The following is a description of a gene set: studied in species Homo sapiens Genes up-regulated in macrophages: untreated versus 48h after M. bovis BCG infection. from publication Qualls JE, Neale G, Smith AM, Koo MS, DeFreitas AA, Zhang H, Kaplan G, Watowich SS, Murray PJ (PMID 20716764) Human Gene Set: GSE22935_UNSTIM_VS_48H_MBOVIS_BCG_STIM_MACROPHAGE_UP Nitric oxide (NO) produced by macrophages (MØs) is toxic to both host tissues and invading pathogens and its regulation is therefore essential to suppress host cytotoxicity. MØ arginase 1 (Arg1) inhibits NO production by competing with NO synthases for arginine, the common substrate of NO synthases and arginases. Two signal transduction pathways control Arg1 expression in MØs. First, a MyD88-dependent pathway induces Arg1 in intracellular infections, while a second Stat6-dependent pathway is required for Arg1 expression in alternativelyactivated MØs. We found that mycobacteria-infected MØs produce soluble factors that induce Arg1 in an autocrine-paracrine manner via Stat3. We identify these factors as IL-6, IL-10 and GCSF. We further establish that Arg1 expression is controlled by the MyD88-dependent production of IL-6, IL-10 and G-CSF rather than cell intrinsic MyD88 signaling to Arg1. Our data reveal the MyD88-dependent pathway of Arg1induction following BCG infection requires Stat3 activation and may result in the development of an immunosuppressive niche in granulomas due to the induced Arg1 production in surrounding uninfected MØs, and this is the list of marker genes: FAM3D, NAAA, RELN (reelin), GSTT2, THTPA, TBC1D32, CAMKK1, RYR3, ALX1, KLF1, DIO3OS, KIAA0930 (NCBI Gene Id 50610), SLC38A3 (NCBI Gene Id 10991), SMYD1, EFHC2, ATP2C2, SH3GL3, CLTB, OTOS, NCF1, PLXNA3, OLR1, CTNNA2, LYNX1, IFITM5, GPR39, FZD1, EXTL1, CDH23, MYOZ3, B3GALT6, C15orf39, GPX4, SERPINC1, PKP1, TRAPPC6B, MMAB, CD79B, NOS3, PRELP, IMPA1, EYA2, COL19A1, FAM170B, UNC119, AZIN2, DYNC2I1, GLRB, LRAT, CA3, LYRM7, HIF3A, MESD, NRGN, AKAP11, ADAM19, VILL, CPNE6, CPA5, HLA-DMB (NCBI Gene Id 3109), SMARCD3, CAMK2N1, IZUMO1R, SLC17A2, EXPH5, NPAS3, NTNG1, MRPL3, FIBP, TRAPPC6A, EDIL3, RAB42, FILIP1, HIC1, ESD, EFCAB12, AK4, TEX26, GFI1, HOXD10, SARDH, SLC36A3, TBL1XR1, NT5E, NAALAD2, PSMA8, PELI2, NES, SLC6A20, UNC93B1, DLX3, PHTF2 (putative homeodomain transcription factor 2), SPDYA, TMEM191C, POU3F4, FAM131C, MXI1, GSPT2 (NCBI Gene Id 83029), ENSG00000285566, TNK2, RPS19, ASB3, C17orf99, MAP1LC3A, SLC16A10, DACT2, SLC35D2, PIM3, CHRNA6, A4GALT, SEPTIN12, PHYHIPL, AASS, CLCN1, ARHGEF38, SLAMF6, ALDH1A3, DACH2, DMRTA1 (NCBI Gene Id 64125), AUTS2 (activator of transcription and developmental regulator AUTS2), HBE1, GPR12, PDE4D, NUDT16L1 (NCBI Gene Id 84309), ATG9B, CELF6, P2RX7, IRX6, PPP1R1A, RRAS, ARMC9, SLCO4C1, CELF2, VSX2, ZAN (NCBI Gene Id 7455), ATP5F1D, EGFL8, LMNTD2, YIF1A, COL10A1, TGFB3, NDUFA7, SELENBP1, KIF15, TBC1D2, FAM221B, SHROOM3, ASB12, SORCS2, ARFIP2, NOX4, ATP5F1A (ATP synthase F1 subunit alpha), IFNGR2, SERPINB8, MDH2, IL36A, MSTO1, TEP1, MRRF, CFAP20DC, NECTIN2, TSPYL5, RCE1, TMEM273, IQCG, MED4, NSMCE1-DT, SVIP, TMTC3, LHX1 (NCBI Gene Id 3975), AK7, LZTFL1, SLCO1A2, EMILIN3, KRT13, ABCA4, MGAT4C, DYDC2, ZCCHC17, N4BP2, TMEM230, MRPL23, NRIP1, P4HTM, DIABLO, GRK4, MISP, SCN9A, MGST2, GPIHBP1, ADAMTSL1, PSCA, MTG1, INS, DAB2IP, PRG3, ATP13A5, GSTM3, ARL10, MATCAP1